Given this list of marker genes TCN2, LGALS3BP, SDC3 (NCBI Gene Id 9672), ALDH1A1, SERPING1, NCF1C, NCF1, AIM2, SIGLEC1, CCR1, MARCO, here is a description of the gene set: Genes up-regulated in dendritic cell 3d vs 0d in adults (18-49) after exposure to inactivated monovalent influenza A/Indonesia/05/2005 H5N1 split-virus vaccine, time point 3D, administered i.m. from publication Howard LM, Hoek KL, Goll JB, Samir P, Galassie A, Allos TM, Niu X, Gordy LE, Creech CB, Prasad N, Jensen TL, Hill H, Levy SE, Joyce S, Link AJ, Edwards KM (PMID 28099485) species: Homo sapiens Human Gene Set: HOWARD_DENDRITIC_CELL_INACT_MONOV_INFLUENZA_A_INDONESIA_05_2005_H5N1_AGE_18_49YO_3DY_UP BACKGROUND: Vaccine development for influenza A/H5N1 is an important public health priority, but H5N1 vaccines are less immunogenic than seasonal influenza vaccines. Adjuvant System 03 (AS03) markedly enhances immune responses to H5N1 vaccine antigens, but the underlying molecular mechanisms are incompletely understood. OBJECTIVE: We compared the safety (primary endpoint), immunogenicity (secondary), gene expression (tertiary) and cytokine responses (exploratory) between AS03-adjuvanted and unadjuvanted inactivated split-virus H5N1 influenza vaccines. In a double-blinded clinical trial, we randomized twenty adults aged 18-49 to receive two doses of either AS03-adjuvanted (n = 10) or unadjuvanted (n = 10) H5N1 vaccine 28 days apart. We used a systems biology approach to characterize and correlate changes in serum cytokines, antibody titers, and gene expression levels in six immune cell types at 1, 3, 7, and 28 days after the first vaccination. RESULTS: Both vaccines were well-tolerated. Nine of 10 subjects in the adjuvanted group and 0/10 in the unadjuvanted group exhibited seroprotection (hemagglutination inhibition antibody titer > 1:40) at day 56. Within 24 hours of AS03-adjuvanted vaccination, increased serum levels of IL-6 and IP-10 were noted. Interferon signaling and antigen processing and presentation-related gene responses were induced in dendritic cells, monocytes, and neutrophils. Upregulation of MHC class II antigen presentation-related genes was seen in neutrophils. Three days after AS03-adjuvanted vaccine, upregulation of genes involved in cell cycle and division was detected in NK cells and correlated with serum levels of IP-10. Early upregulation of interferon signaling-related genes was also found to predict seroprotection 56 days after first vaccination. CONCLUSIONS: Using this cell-based systems approach, novel mechanisms of action for AS03-adjuvanted pandemic influenza vaccination were observed. TRIAL: ClinicalTrials.gov NCT01573312.